The following is a description of a gene set: species: Mus musculus Mouse Gene Set: GOBP_NEGATIVE_REGULATION_OF_INTRINSIC_APOPTOTIC_SIGNALING_PATHWAY_IN_RESPONSE_TO_DNA_DAMAGE_BY_P53_CLASS_MEDIATOR Any process that stops, prevents or reduces the frequency, rate or extent of intrinsic apoptotic signaling pathway in response to DNA damage by p53 class mediator., and this is the list of marker genes: Cd74, Zfp385a, Mif, Bcl2l12, Kdm1a, Cd44, Triap1, Ell3, Muc1, Marchf7, Sirt1, Atad5